Given this list of marker genes Zfp97, Dbf4, Oasl2, Trafd1, Pcyt2, Rmdn3, Cenpn, Dclk1, Parp9, Lgals9, Fam3d, Sdc3, Prkcq, Krt20, Irf7, Ass1, Isg20, Kif5c, Ddx60, Apaf1, Rell1, Plpbp, Rsad2, Gli3, Pml, Mansc1, Lgals8, Fkbp1b, here is a description of the gene set: species: Mus musculus Cytokines mediate cell-cell communication in the immune system and represent important therapeutic targets. A myriad of studies have highlighted their central role in immune function, yet we lack a global view of the cellular responses of each immune cell type to each cytokine. To address this gap, the authors created the Immune Dictionary, a compendium of single-cell transcriptomic profiles of more than 17 immune cell types in response to each of 86 cytokines (>1,400 cytokine-cell type combinations) in mouse lymph nodes in vivo. A cytokine-centric view of the dictionary revealed that most cytokines induce highly cell-type-specific responses. For example, the inflammatory cytokine interleukin-1β induces distinct gene programmes in almost every cell type. A cell-type-centric view of the dictionary identified more than 66 cytokine-driven cellular polarization states across immune cell types, including previously uncharacterized states such as an interleukin-18-induced polyfunctional natural killer cell state. from publication Cui A, Huang T, Li S, Ma A, Pérez JL, Sander C, Keskin DB, Wu CJ, Fraenkel E, Hacohen N (PMID 38057668) Genes positively differentially expressed in cell type: eTAC (extrathymic Aire-expressing cell) upon treatment with cytokine: IFN-β in mouse lymph nodes in vivo. Mouse Gene Set: CUI_ETAC_IFNB_RESPONSE_UP